Given this list of marker genes FBN1, C12orf57, COL11A1 (NCBI Gene Id 317718), MOCS1, PAX2, COL2A1, MOCS2, GNAQ, here is a description of the gene set: Human Gene Set: HP_LENS_LUXATION species: Homo sapiens Complete dislocation of the lens of the eye. Lens luxation